Given this list of marker genes CUX1, BMP4, KRTAP2-4, KRTAP6-1, DKK3, SMAD1, DLX3, CD200, KRT15, KLK13, SFRP1, NOTCH1, EGR2, EGFR (NCBI Gene Id 1956), SMAD4, LEF1, WNT5A, KLK4, KLK7, NOTCH2, TCF3 (transcription factor 3), FOSB (FosB proto-oncogene, AP-1 transcription factor subunit), NFATC1, GLI2, IGFBP5, LRIG1, PERP, SOX9, MSX1, KITLG, RUNX3, KRTAP8-1, KLK6, FOXQ1, BMPR1A, FOXE1 (NCBI Gene Id 7081), FOXN1, S100A4, PROM1, JUN, KLK14, CD34, LHX2, NR3C1, RBPJ, CTNNB1, FOS, KRTAP15-1, LGR5, SOX2, IGF1, ADAMTS20, PHLDA1, TP63, GPRC5D, SOSTDC1, GTPBP4, CASP14, DSC2, FST, CCN2, HR, DKK1, SPINK6, BMP6, BCL11B, SPINK5, DSG1, FZD1, ZBTB16, KLK5, NFKB1, ADAM17, GJB6, MSX2, KRTAP3-3, KRT19 (NCBI Gene Id 3880), DKK4, GAS1, HOXC12, GATA3, ELANE (elastase, neutrophil expressed), TCF4, IFNG, DSG4, WIF1, GSDMA, here is a description of the gene set: Human Gene Set: WP_HAIR_FOLLICLE_DEVELOPMENT_CYTODIFFERENTIATION_STAGE_3_OF_3 studied in species Homo sapiens Hair follicle development: cytodifferentiation - stage 3 of 3